The following is a description of a gene set: studied in species Mus musculus Covalent attachment of the ubiquitin-like protein UFM1 to a protein, forming an UFM1 chain. Mouse Gene Set: GOBP_PROTEIN_POLYUFMYLATION, and this is the list of marker genes: Ufm1, Ddrgk1, Ufc1 (NCBI Gene Id 66155), Ufl1, Uba5